Given this list of marker genes Ace, Card9, Asns, Inhba, Rpl27, Pf4, Aifm1, Slc12a3, Scnn1b, Stk39, Sgk1 (NCBI Gene Id 20393), Crh, Cdkn1a, Scnn1a, Scnn1g, Cybb, Nr3c2, here is a description of the gene set: species: Mus musculus Mouse Gene Set: GOBP_RESPONSE_TO_ALDOSTERONE Any process that results in a change in state or activity of a cell or an organism (in terms of movement, secretion, enzyme production, gene expression, etc.) as a result of an aldosterone stimulus.